Given this list of marker genes Aldh1b1, Aldh1a2, Aldh2, Aldh3b3, Aldh4a1, Aldh3a1, Aldh7a1, Aldh1l1, Aldh1l2, Rdh11, Aldh1a1, Aldh16a1, Aldh1a3, Aldh1a7 (aldehyde dehydrogenase family 1, subfamily A7), Aldh3b1, Adh4 (alcohol dehydrogenase 4 (class II), pi polypeptide), Aldh3b2, Adh5, Aldh9a1, Aldh3a2, here is a description of the gene set: Catalysis of the reaction: an aldehyde + NAD(P)+ + H2O = an acid + NAD(P)H + H+. studied in species Mus musculus Mouse Gene Set: GOMF_ALDEHYDE_DEHYDROGENASE_NAD_P_PLUS_ACTIVITY